Given this list of marker genes PARP3, SLC9A1, ADSS2, LPCAT3, MMP7, MS4A18, TUBA1C, HMGB1, CPEB1, RELL1, GRPR, LRRTM4, ANKRD13C, ZNF701, ZNF415, EFHC1 (NCBI Gene Id 94915), PLXNA2, SPRY2, SUMO1, CCDC43, JPH1, ERBB3, ARL17A, IGSF5, FAM83H, TMIGD1, SYN1, TFB1M (transcription factor B1, mitochondrial), CDH8, SUCLA2, MTRR, IGDCC3, TBL1XR1, here is a description of the gene set: studied in species Homo sapiens from publication Chen Y, Wang X (PMID 31504780) Genes predicted to be targets of miRBase v22 microRNA hsa-miR-4433b-3p in miRDB v6.0 with MirTarget v4 prediction scores > 80 (high confidence targets). Human Gene Set: MIR4433B_3P